Given this list of marker genes Atp5f1b, Atp5pd, mt-Atp8, Atp5po, Dmac2l (distal membrane arm assembly component 2 like), Atp5mk (ATP synthase membrane subunit k), Atp5mc1 (NCBI Gene Id 11951), Atp5pf, Atp5mc2, here is a description of the gene set: Reactome Pathway: Cristae formation electronically inferred by orthology from the curated human pathway part of: Mitochondrial biogenesis This event has been computationally inferred from an event that has been demonstrated in another species.<p>The inference is based on the homology mapping from PANTHER. Briefly, reactions for which all involved PhysicalEntities (in input, output and catalyst) have a mapped orthologue/paralogue (for complexes at least 75% of components must have a mapping) are inferred to the other species. species: Mus musculus